The following is a description of a gene set: studied in species Homo sapiens from publication Unterman A, Zhao AY, Neumark N, Schupp JC, Ahangari F, Cosme C Jr, Sharma P, Flint J, Stein Y, Ryu C, Ishikawa G, Sumida TS, Gomez JL, Herazo-Maya JD, Dela Cruz CS, Herzog EL, Kaminski N (PMID 38717443) Human Gene Set: UNTERMAN_PROGRESSIVE_VS_STABLE_IPF_B_CELL_DN Thirty-eight PBMC samples from 25 patients with IPF and 13 matched controls yielded 149,564 cells that segregated into 23 subpopulations. Classical monocytes were increased in progressive and stable IPF compared to controls (32.1%, 25.2%, 17.9%, respectively, p<0.05). Total lymphocytes were decreased in IPF vs controls, and in progressive vs stable IPF (52.6% vs 62.6%, p=0.035). Tregs were increased in progressive vs stable IPF (1.8% vs 1.1% of all PBMC, p=0.007), although not different than controls, and may be associated with decreased survival (P=0.009 in Kaplan-Meier analysis; P=0.069 after adjusting for age, sex, and baseline FVC). Flow cytometry analysis confirmed this finding in an independent cohort of IPF patients. Fraction of Tregs out of all T cells was also increased in two cohorts of lung scRNA-seq. CCL22 and CCL18, ligands for CCR4 and CCR8 Treg chemotaxis receptors, were increased in IPF. The single-cell atlas of the peripheral immune system in IPF, reveals an outcome-predictive increase in classical monocytes and Tregs, as well as evidence for a lung-blood immune recruitment axis involving CCL7 (for classical monocytes) and CCL18/CCL22 (for Tregs). (From Abstract) Genes downregulated in B cells from Progressive Idiopathic Pulmonary Fibrosis Patients vs. Stable Non-Progressors, and this is the list of marker genes: IGHA1, JUNB, RPS26, IGHG2, HERPUD1, CD83, HLA-C, IGHG1